The following is a description of a gene set: studied in species Homo sapiens The chemical reactions and pathways resulting in the formation of monocarboxylic acids, any organic acid containing one carboxyl (-COOH) group. Human Gene Set: GOBP_MONOCARBOXYLIC_ACID_BIOSYNTHETIC_PROCESS, and this is the list of marker genes: PER2, ALDH1A3, STARD4, CES1, ACSM3, SLC45A3, ABCD2, STAR, LDHC, TRIB3, ACOT7, PTGES, CEACAM1, HSD17B8, KLHL25, OSBPL7, ACADL, ACSL4, ACSF3, CTHRC1, MTHFD2 (NCBI Gene Id 10797), PDK4, ALOX15, AKR1C4, MTHFD1L, PTGIS, ELOVL7 (NCBI Gene Id 79993), HSD3B7, LIAS, INSIG1, DCAF5, PRKAA1, PTGDS, ACOX2, LPL, KAT2B, ELOVL6, CYP2E1, PIBF1, IDO1, PNLIPRP3, GATD1, OSBPL9, MIR30C1, PRXL2B, ACACA, MIR342, APOC2, XBP1, APOC3, PNLIPRP2, GSTM2, PLA2G10, ABHD3, EIF6, DHRS9, CBR1, ACSS2, OXSM, PTGES3, ACOT8, MGLL, NR1H4, SCAP, ACOX1, ABCD3, SCD5, ACSM2B, EDN1, SLC27A2, MLXIPL (MLX interacting protein like), THNSL2, CYP1A1, GPIHBP1, OSBPL3, SLC27A5, FADS6 (fatty acid desaturase 6), PARK7, AKR1C3, HPGDS, MIR33A, PLP1, ACACB, PKLR, HSD17B10, APOA5, CYP2C9, ACSBG2, ABCB11, OLAH, CYP7B1, ERRFI1, TECR, AVPR1A, HSD17B4, ELOVL2, OSBPL2, FADS3, PRKAG3, NR1D1, GSTM1, ABCD1, SIRT1, GATM, INSIG2, SHMT2, ALOX12, CYP27A1, ASAH2, MIF, ERLIN1, HSD17B12, TECRL, AMACR, ELOVL3, APOA4, WDTC1, ACOT4, HACD1, BAAT, MID1IP1, ABHD2, APOC1, LIPC, ALOXE3, CYP3A4, MIR96, FABP5, GIP, DEGS1, IL1B, ACADVL, ACSL1, SCD, PLA2G3, HACD4, PTGS2, ALDH8A1, PRKAG1, ELOVL5, GAMT, PNPLA8, NR1H2, MIR132, PNLIPRP1, AKR1D1, SRR, FADS2, CBR4, HTD2, OSBPL6, MIR548P, HACD3, NR1H3, ACSBG1, PTGS1, BRCA1, HACD2, ACMSD, CYP1A2, PRKAB2, ELOVL4, ABHD1, RDH10, MLYCD, PECR, CYP2C8, ACSM5, FGFR4, SCP2, FASN, ACSM1, PRKAA2, MCAT (NCBI Gene Id 91700), QKI, FADS2B, ELOVL1, DAGLB, EHHADH, CYP2D6, ERLIN2 (ER lipid raft associated 2), MIR185, RBP1, LIPG, TMEM135 (NCBI Gene Id 65084), CYP46A1, FGF19, GPX4, MIR182, TBXAS1, ALOX12B, PLA2G4F, CYP8B1 (NCBI Gene Id 1582), GSTP1, EDN2, PROX1, LPGAT1, CD74, CYP39A1, ALDH1A2, UBR4, PLA2G1B, DECR2, PRKAG2, ALOX15B, OSBP, AVP, MECR, PNLIP, SIRT2, ACSM4, FA2H, SDS, KMO, PLAA, HOGA1, ACLY, FADS1, ACSM6, MALRD1, MIR204, MIR766, PLA2G4A, ANGPTL4, ACSM2A, PRKAB1, CYP7A1, PTGES2, LTC4S, NDUFAB1, OSBPL1A, ALOX5, GSTM4, PRMT3, ACSS1